Given this list of marker genes COQ6, TMEM91, JAML, TIMM9, LINC02763, TMC8, BPIFB5P, RERE, KIF2C, RPS14, FBXW9, ZNF524, CFAP157, LINC00926, MCM7, PELATON, ATP8A2, TMC6, WSCD2, LASP1, ATP5F1D, CHCHD10, LINC02652, CDC42BPG, MFSD12, PLA2G12A, COQ3 (NCBI Gene Id 96592), ECE1, RPL37A, MIR607, GEMIN6, ENAM, EML2, TMEM214, SARDH, COL15A1 (NCBI Gene Id 1306), CCR5, LINC01096, LOXL4, CYP2AB1P, PHOSPHO1, PLLP, LUCAT1, GTPBP3, ZGLP1, NCOA7, KSR1, UNC93B1 (unc-93 homolog B1, TLR signaling regulator), RANBP9, GAS2L1P2, RNU2-72P, ZZEF1, NUCKS1 (NCBI Gene Id 64710), ASAP3, LLGL2, DNAI4, RABGGTA, ITGA3, ST6GALNAC6, ACTL8, CIITA, APBA3, LPAR2, ICMT-DT, RPS29, ELOF1, SELPLG, HEATR3, SLC29A3, CORO1C, MAPKAPK5, SUOX, TAF7, ARHGEF1, LINC01012, POLR1B, PISRT1, TILAM, VSTM2L, GPSM2, TSC1, SCNN1D, EMID1, CCDC22, CORO7, VPS72, C1orf127, ACTN4, SYN1, HMGN2P34, MUL1, MARF1, COL27A1, ADCY9, NUDT21, FGF17, SEZ6, DPP3-DT, MLLT1, PSMB2, FHIP1B (NCBI Gene Id 84067), SLF2, DAGLB, ATP6V0A2, LINC02953, HPS6, SYNPO2L, ALDH8A1, ZNF184, TMEM19, TCEA1, CATIP-AS1, GPR160, MIR6860, NECAB2, ANG, GATA1, GGT1, DRG2, HMCN2, SLC25A20, TBC1D10A, RPS18P1, RPL6, CLCC1, NCAPH, CFAP107, CD151, CHMP6, C1QTNF6, CNN1, CFAP57, NOX1, GPR17, RWDD2B, NKPD1, GSDME, C19orf25, TOX2, EARS2, ICAM1, STAG2 (NCBI Gene Id 10735), CHRD, RNU4-2, KMT5A, RNU6-777P, CRTAP, NFIC, CACNG5, HNRNPM, HK1, UBFD1, ATP1A1-AS1 (NCBI Gene Id 84852), TMEM134, PHLDB1, NAV2, DMPK (DM1 protein kinase), PPID, VPS37D, RPL22P19, ZNF638, KLK15, GIT1, KIAA0586 (KIAA0586), LINC01446, PEX14, ENSG00000212590, SCARB1, MINDY1, MIR6782, ALDH3B1, CYP4F12, ZMIZ1, HKDC1, MGAT1, GSN, ABHD16A, TRMT1, MYO15B, CCDC61, TLE2, GDPD5, SORBS1, NEK6, MIR145, PNKP (polynucleotide kinase 3'-phosphatase), PLBD2, CNTNAP1, MCOLN1, CSF3R, RPL29P34, NIPA2, PRRT3, CCR10, COL18A1, FAM200A, UTP25, PKD2L2, PGPEP1, SMARCD2, RITA1, RAB27A, FCHO1, GAMT, HGFAC, NR6A1, PKN1, PAM16 (NCBI Gene Id 51025), GNA15-DT, SMPD4, HLA-E, EPHB2, HPS4, FNDC4, NIBAN2, ENSG00000228044, ACBD6, PIK3AP1 (NCBI Gene Id 118788), DNASE2, ZNF234, NEBL, SLC38A10, ZSWIM4, GRIP2, RASGRP2 (RAS guanyl releasing protein 2), ARPC4-TTLL3, PLPP3, CIBAR2, ASTILCS, SUPV3L1, NBEAL1, PRMT1, WDR12, WDR43, SMASR, LSM12, DAZAP1, UBASH3A, PTPRA, TARS2, RASSF5 (NCBI Gene Id 83593), CYGB, ZNF24, CATSPER1, TMEM132D-AS1, DMAC2, UBE2Q2P13, PHLDA2, SRPK1 (NCBI Gene Id 6732), MPO, KCTD21, GTF2H4, NFE2, SWSAP1, CDA, SLCO2B1, CTDSP1, PROSER2, MAPRE1, SDHAF4, NGEF, RAB2A, TP53RK-DT, CLASRP, TNS4, EHBP1L1, SPC24, C17orf99, LCP2, TMEM98 (transmembrane protein 98), GAREM2, MIR6881, STX1A, RNASE4, ECHDC2, LINC02777, KTN1, LGALS1, ACTL6A, PHTF2, MRC2, PDLIM7, PRSS16, URAHP, CYB5D2, COASY, RHBDF2, SAE1, SLC22A8, WDR45, SHFL, LINC02971, TUFM, CERS2, SMAD3, DTD1, IER5L-AS1, TREX2, ISG20, USP30-AS1 (NCBI Gene Id 100131733), SERHL, PSMD9, PCSK4, CCDC43, TXNRD1, ABCB9, FAM157C, PLAUR, FEM1A, TRAPPC14 (NCBI Gene Id 55262), CNGB1, ZNF131, PI4K2A, LINC01567, OAS3, PTK2B (NCBI Gene Id 5748), HTR6, ARAF, LILRB4, STK17B, SMPD4P1, SLC30A6, ELN-AS1, MIR8063, CSH1, CHRNA2, MIR3945HG, RBM47, C8orf76, ELANE, PSMB3, RN7SKP91, CCT4, MIX23P5, HDGFL3, MYO18B, DPP3, CLLU1-AS1, SNRPC, VAV1, MFSD6, MIR7850, PKD2L2-DT, CPT1C, HAUS7, RANBP1, FXN, PRKD2, TKT, FANCC, CASTOR1, CTDSPL2, EAPP, XKR8, FBN3, ZNF175, SLC29A2, MIR4487, BRAT1, H3C9P, PHF19, TRMT2A, LRRC51, SLC25A23, ZSCAN25, GADD45GIP1, GNG7, ICMT, TAF1C, TULP1, ZNF3, HSPB1P2, ENSG00000258702, SYCP2L, ZW10, MRPS15, AKR7A2, PDE4A, DNM2, SLC25A24, LGALS4, LINC02395, MATN1-AS1, MIR548AW, ZNF764, SRC, BCL9L, SEPTIN9, TM9SF5P (NCBI Gene Id 100420958), IL21R, CSMD1, RTF1, TESC, LINC01398, GFI1B, PFAS, PNN, CRYBB1, ITGB4, CRADD, PIGBOS1, PRKCD, MTURN, ENSG00000267764, CEP164, MRPL53P1, PIK3R2, NOSIP, LDLRAD2, SETD1A, SMU1, TRIM7-AS2, GRAP2, ENSG00000226249, PSME2, ASS1, PLA2G4E, GTF3C1, SGSM1, GTF2E2, B4GALT4, MOSPD3, GP9, EIF5A, SEMA7A (NCBI Gene Id 8482), SIPA1L3, AXL, MYO1H, KRT4, RNF14, SHD, CERS5, TOR1A, AKT2, GABPB2, ZNF346, DDX54, RAC1, CCDC120, BZW1, RILPL2, SUPT4H1 (NCBI Gene Id 6827), APOC1, CMBL, TMEFF1, MIR4656, ADGRB2, DPP9, NAA20, RPL21P29, VARS2, TBX6, BICRAL, RAP1GAP, ILVBL, RPL36, PUS7L, TPK1, ANAPC15, POLD1, RNU1-16P, ENC1, BCL3, ADRM1 (ADRM1 26S proteasome ubiquitin receptor), TMEM119, DPF1, AAAS, BRAP, CCNB1IP1, USB1, GRSF1, COMMD5P1, MARK4, YIF1B, AP2A2, ADAMTS10, FLCN, ARPC4, TYROBP, ALDH1A1, EHD2 (NCBI Gene Id 30846), XRCC1, MATK, NMUR1, SNUPN, ATP6V0E2, KDSR, FBXO27, RNU6-558P, ENSG00000254746, SHANK1, RPS24, METTL14, LINC02812, LRBA, MACROD1, RASAL1, IL1RL1, SPATA2 (spermatogenesis associated 2), ZBTB38 (NCBI Gene Id 79779), PADI4, ADGRE1, SRCIN1, NDUFAB1, KEAP1, PIGU, KRT15, ID1, PAK4, CDK5RAP2, USP35, ADCY6, MIR1205, NBEAL2, ENSG00000212144, BTN3A1 (butyrophilin subfamily 3 member A1), MYOM3, LINC00240, GCKR, SNX29, TENT2, QDPR, NCOR2, ADCY7, AP3B1, CC2D1A, UBR5, VTRNA1-3, NATD1, OAT, RNF10P1, MAPT, ARHGAP45, RPS18, NSMCE1-DT, GPR108, FLVCR1, TP53I11 (tumor protein p53 inducible protein 11), MIR6089, ZMPSTE24-DT, RNASE11, VEPH1 (NCBI Gene Id 79674), PYGM, NLRX1, C1orf167, NIFKP9, SEMA4B, FLII, MEGF9, N4BP1, PCCB, SMYD3, DOK4, ZFP69 (ZFP69 zinc finger protein), PRKACA, RPL30P7, RN7SL449P, RNF216P1 (ring finger protein 216 pseudogene 1), METTL14-DT, KLHL41, RALB, SMARCC2 (SWI/SNF related, matrix associated, actin dependent regulator of chromatin subfamily c member 2), GTF2E1 (general transcription factor IIE subunit 1), F2 (coagulation factor II), NDST1, AP4M1, CBR1-AS1 (CBR1 antisense RNA 1), KPNB1, KCNK5, STARD9, CCDC194, DNHD1, SDHAP4, CCNT1, MIDN, ADA, INTS6-AS1, ALKBH7, SPPL2C, NDUFA3, CCDC162P, CDC25B, ATP6AP1L, POFUT1, LINC02396, FKBP1A, BEGAIN, SNPH (syntaphilin), ENSG00000187185, ACOX2, CDC45, LAPTM5, CLU, PDLIM1, ZC3H14, MADCAM1, HPN, ADAMTS14, OGG1, CTSS, ANAPC5, MIR3681HG, TIPARP, CCDC117, CACNA1A (calcium voltage-gated channel subunit alpha1 A), LDLRAP1, RAPGEF1, RNU6-339P, PRUNE1, ZNF227, RHOT1P3, CARHSP1, CDH5, ZFP36L1, CTSB, KCNK15-AS1, FCGRT, AARS2, LINC01503, SYT3, MYO15A, TRABD, FRRS1, CACTIN, GSTA4, ANKRD13C, GADD45B, PSMB6, CYRIB, LINC02356, CEACAM19, RNU6-1237P, RAVER1, LINC02625, PHYH, CD276, ENSG00000283573 (novel transcript), MACF1, DGAT2, PLEKHG2, UNC13A, PAOX, FBLN2, AQP1, CUTC, ENSG00000201733, ELK3, ISCA1, WDR82, ZNF839, TMPRSS6, SRXN1, ABR, EVA1B, KANSL3, MRPL54, B2M, ZNF207, MFNG, NOVA2, here is a description of the gene set: species: Homo sapiens Human Gene Set: ADNP_TARGET_GENES Genes containing one or more binding sites for (ADNP) in their promoter regions (TSS -1000,+100 bp) as identified by GTRD version 20.06 ChIP-seq harmonization. from publication Yevshin I, Sharipov R, Kolmykov S, Kondrakhin Y, Kolpakov F (PMID 30445619)